Given this list of marker genes USP25, PPP1R11, PRR3, ZNF704 (NCBI Gene Id 84737), EIF4G3, ZNF281, PRG4, ADD3, MGP, LDB3, KHDRBS1, TRDMT1, DDX55 (DEAD-box helicase 55), EMSY, CD81, AQP4, HNRNPA3, WDR44, OGN, RGS7BP, ASZ1, PGM5, CCSER2, ZCCHC7, RNF217, AMER2, ZNF331, RBFOX3, SPRY1, SOCS6, PPM1B, AMDHD1, TRAF3IP1, PPM1L, MBOAT2, MICAL2, CERT1, TMEM30A, FAT3, TAX1BP3, AZIN1, ASPH (aspartate beta-hydroxylase), CTBP2, PATJ, IPO11, PCDH17, ACAD8, DICER1, NDRG4, ZDHHC21, LMO4, EIF4E3, TFF3, HOOK3, CPEB2, PCBP1, CA12, GPR12, PCDH7, RBAK, GET1 (guided entry of tail-anchored proteins factor 1), ZNF567, LYZ, CFDP1, SKP2, PAX4, STUM, PGPEP1L, SUB1, KCNH7, CBLL1, KHDC4, CAPN6, MBNL1, ZNF275, DCAF8L1, CLN3, USP10, PANK2, LRRTM2, RNLS, MAP3K20, AMACR, CDKN1B, KMO, COL4A1 (collagen type IV alpha 1 chain), GMDS, ANKZF1, AEBP2, TPM1, PLCB1, ITPR1, RREB1, NTF4, MDM1, CEP76, LRCH2, HNMT, ALCAM, DNASE1L1, LAMB1, MAL2, KCTD8, ATP8A2, TLCD4, CPEB1, P2RY1, C4orf3, KPNB1, CYBRD1 (cytochrome b reductase 1), PURG, A1CF, SSBP2, RABGAP1L (NCBI Gene Id 9910), SLC39A6, OSBPL8, ATP2C2, NIPSNAP2, SPMIP4, PYCR2, TRIQK, ABO, EIF3M, MIPOL1 (mirror-image polydactyly 1), SLC12A1, RFX7, ACAP2, SGO1, MEGF11, GNB4, MID1, TEX30, OPRK1, CAMK2N1, PRKACB, here is a description of the gene set: from publication Chen Y, Wang X (PMID 31504780) Genes predicted to be targets of miRBase v22 microRNA hsa-miR-8070 in miRDB v6.0 with MirTarget v4 prediction scores > 80 (high confidence targets). species: Homo sapiens Human Gene Set: MIR8070